The following is a description of a gene set: studied in species Mus musculus Assembly of gap junctions, which are found in most animal tissues, and serve as direct connections between the cytoplasms of adjacent cells. They provide open channels through the plasma membrane, allowing ions and small molecules (less than approximately a thousand daltons) to diffuse freely between neighboring cells, but preventing the passage of proteins and nucleic acids. Mouse Gene Set: GOBP_GAP_JUNCTION_ASSEMBLY, and this is the list of marker genes: Cav1, Hopx, Gjc1, Gjb2, Agt, Cntnap2, Tbx5, Irx3, Aplnr, Il1b, Gja5, Gjd3, Gjb6, Ace, Ace2, Pkp2, Ctnna1